Given this list of marker genes H2BC3, H2AC8, H2BC6, H2BC26, H2AC7, SFN, H2BC4, YWHAZ, H4C12, H3-3A, H2BC5, YWHAB, H4C2, H2BC14, H2BC13, H3C11, H3C2, YWHAG, MYH14, YWHAH, H3C7, H2AC14, H4C9, PKN1, YWHAE, H3-3B, H2BC15 (NCBI Gene Id 8341), H4C4, H2BC11, AR, RHOB, PDPK1, CDC25C, H2BC7, PPP1R14A, PKN2, H4C5, H2BC1, H2AC18, H2AJ, H3C10, H3C4, H3C8, RHOA, H3C14, KDM1A, H3C15, H4C15, H4C11, MYH9, NCOA2 (NCBI Gene Id 10499), H2BC17, PPP1R12B, H3C1, H2BC21, H2BC9, H4C16, H2BC12, H2AB1, KLK3, H2AC6, H3C6, H3C13, H2AC20, PKN3, H4C1, H4C13, H2AC19 (H2A clustered histone 19), RHOC, MYL12B, PPP1R12A, H4C8 (H4 clustered histone 8), MYH10, PPP1CB, H2BC8 (H2B clustered histone 8), H2AX, H4C3, YWHAQ, PAK1, MYH11, H3C12, KLK2, H2AZ2, MYL6, H2BC10, H4C6, H2AC4, H4C14, MYL9, RAC1, H3C3, KDM4C, H2BC12L, here is a description of the gene set: species: Homo sapiens Human Gene Set: REACTOME_RHO_GTPASES_ACTIVATE_PKNS RHO GTPases activate PKNs